The following is a description of a gene set: The removal of an acetyl group from an acetylated lysine residue in a peptide or protein. Human Gene Set: GOBP_PEPTIDYL_LYSINE_DEACETYLATION studied in species Homo sapiens, and this is the list of marker genes: SIRT3, HDAC4, HDAC9, SIRT4, SIRT2